The following is a description of a gene set: Human Gene Set: MIR4796_5P Genes predicted to be targets of miRBase v22 microRNA hsa-miR-4796-5p in miRDB v6.0 with MirTarget v4 prediction scores > 80 (high confidence targets). studied in species Homo sapiens from publication Chen Y, Wang X (PMID 31504780), and this is the list of marker genes: CTNNA3, MYO5B, SCAF8, FBXO47 (F-box protein 47), PDE11A, FKBP1A, CYP27C1, CCDC186, BLTP2, CUX2, MAIP1, B4GALT6, CYTIP, SNTB1, RNF152, PMP2, WDHD1, USP31, LMX1A, PCDHB9, NIP7, VWC2, ADH4, ZNF709, IRF2BPL, PCDH18 (NCBI Gene Id 54510), MGAT4A, RPS6KA6, TRAPPC3L, REEP1, AFG1L, ABHD10, HHIP, AUTS2, APC, SLC25A17, ETS1, EDEM3, VCAM1, SNAP25, PLEKHB1, WSB1 (NCBI Gene Id 26118), PAX4, PAX6, LINC03103 (long intergenic non-protein coding RNA 3103), UNK, RTF1, RWDD3, ZNF91, ZNF652, CHD6, CAPS2, PABPC1L2B, FRS2, SLC44A5, C1QL3, EDN3, RANBP3L, SNX12, PREX2, PRDM2, SHROOM3, LEPR, SP100, REV3L, ZNF84, SKP2 (NCBI Gene Id 86997), GAS1, EGF, VEPH1, DUSP16, ASXL3, RND1, FOXN2, CCDC32, DSG2, HIVEP1, SNX25, LAX1, N4BP2L2, TRMT11, ANAPC16, RIMS1, GLS2, TMEFF2, RAB3B, IKZF2 (NCBI Gene Id 51173), SLC16A14, ZNF81, USP42, EPHA7, EXPH5, PACRG, ST6GALNAC5, NOD2, CDYL, LRRC18, ARL8B, ATP8A1